The following is a description of a gene set: Goals/objectives: to identify various gene expression in B cell subsets derived from human PBMC and cord blood Genes down-regulated in B lymphocytes: naïve versus transitional CR2 low. studied in species Homo sapiens from publication Suryani S, Fulcher DA, Santner-Nanan B, Nanan R, Wong M, Shaw PJ, Gibson J, Williams A, Tangye SG (PMID 19965666) Human Gene Set: GSE17186_NAIVE_VS_CD21LOW_TRANSITIONAL_BCELL_DN, and this is the list of marker genes: PPDPF, RAP2B, ENDOG, ACSS2, SLFN13, PDCD10, ESYT2, ACTN2, LRRC75B (NCBI Gene Id 388886), ADD1, KANSL1, USP36, TRMO, UBE2D3, WDR17, SMPD5, JADE1, IL21R, TTC28, PKNOX1, MLLT6 (NCBI Gene Id 4302), PGAP1, RPS19, SMG9, MAP7, STAT5B, ZBTB2, SLC44A2, CASP8, TNK2, RAC2, XPC, SLC20A1, SNHG17, CCM2, PRF1, ZNF81, MTHFD1L, DBP, NT5DC1, SRSF12, METTL27, CMSS1, ZAP70, CCDC30, KIF1B, SLFN12L, CERS4, LY9, SMPD1, TCF12, CTPS2, CBX4, CHST10, DOCK2, POLR3GL, PGM2L1, ANGPTL4, SLC35G1, ENG, EMID1, RUNDC3B, SSBP2, DENND4C, RCSD1, SLC16A1, USP24, ABCA2, LDLRAP1, CCDC82, UTP20, GBP2, TXNIP, SORCS2, SP4, BNIP5, DYRK2, EXD2, C8orf58, IDNK, RALGPS2, IL2RB, SLC6A19, KIAA0040, RBM38, NFATC3, ARL4D, PMS2, GALNT6, TPST2, EPHB6, GAB3, TBC1D25, JAK1, ARL2BP, ICAM2, SLA2, JADE2, SLAIN1, RAB37, MITD1, PCSK4, RNF144A, DNAJC15, H2AJ, SLC25A40, RTP4, RPL36A, DEF6, HDAC7, DIAPH1, IZUMO1R, TTC27, TMEM50A, METTL23, EMP3, MAT2B, ARHGAP1 (Rho GTPase activating protein 1), ARFRP1, DDX11, SESN1, ING1, WDR33, RPSA, SMC4, WWP1, HADH, TMEM9, SETD6, RNF2, PXYLP1 (NCBI Gene Id 92370), GMFG, ESYT1, CTSD, ADAMTS6, ZDHHC15, DLEU7, VPS54 (VPS54 subunit of GARP complex), GPR183, GRIA3, SERPINB6, RP9, ACSBG1, POLRMT, IP6K1, RPS8, PSTK, RPL22L1, TIMP2, STK10, AXIN2, PAXX, PPP2R5A (protein phosphatase 2 regulatory subunit B'alpha), RNF38, CARNS1, EZR, RARG, SMAP2, WDTC1, UTP15, PELI1 (NCBI Gene Id 57334), CNP, FLT3LG, HSDL1 (NCBI Gene Id 83693), TPCN1, ABHD8, TRMT112, ZNF280C, ZHX2, B4GALT1, ZFPM1, IFI27L2, BAIAP3, ELK3, RPS27, TMLHE, LGALS1, SETX, EMG1, MAP3K1, CEP68, SIAH1, CFAP96, RCL1, CACNA2D4, FSD2, KLK8, ARL6IP5, L3MBTL3, FAM3C, CYTH1, IRF2BPL, KRBA1, FYB1, TESC, SDR39U1, MYLIP, MFHAS1, CD79B, RASSF2